The following is a description of a gene set: Human Gene Set: REACTOME_SUMOYLATION_OF_DNA_REPLICATION_PROTEINS SUMOylation of DNA replication proteins studied in species Homo sapiens, and this is the list of marker genes: NUP98 (NCBI Gene Id 51457), NUP205, AAAS, TPR, AURKA, PIAS4, POM121C, NUP43, NUP210, AURKB, NDC1, PIAS3, NUP214, SUMO2, SEH1L, TOP2A, INCENP, SUMO1, RANGAP1, POM121, SUMO3, CDCA8, NUP62, NUP153, UBE2I, NUP50, NUP54, NUP58, NUP85, NUP88, NUP37, BIRC5, NUP160, NUP42, NUP133, NUP155, TOP2B (DNA topoisomerase II beta), PCNA, NUP35, RAE1, TOP1, RANBP2, NUP93, NUP107, SEC13, NUP188